The following is a description of a gene set: studied in species Homo sapiens from publication Indraccolo S, Pfeffer U, Minuzzo S, Esposito G, Roni V, Mandruzzato S, Ferrari N, Anfosso L, Dell'Eva R, Noonan DM, Chieco-Bianchi L, Albini A, Amadori A (PMID 17202376) IFNs are highly pleiotropic cytokines also endowed with marked anti-angiogenic activity. In this study, the mRNA expression profiles of endothelial cells (EC) exposed in vitro to IFN-alpha, IFN-beta, or IFN-gamma were determined. We found that in HUVEC as well as in other EC types genes were upregulated (>2-fold increase) by IFNs, including genes involved in the host response to RNA viruses, inflammation, and apoptosis. Interestingly, genes showed a >5-fold higher induction by IFN-alpha in EC compared to human fibroblasts; among them, the gene encoding the angiostatic chemokine CXCL11 was selectively induced by IFN-alpha in EC along with other genes associated with angiogenesis regulation, including CXCL10, TRAIL, and guanylate binding protein 1 (GBP-1). These transcriptional changes were confirmed and extended by quantitative PCR analysis and ELISA; whereas IFN-alpha and IFN-beta exerted virtually identical effects on transcriptome modulation, a differential gene regulation by type I and type II IFN emerged, especially as far as quantitative aspects were concerned. In vivo, IFN-alpha-producing tumors over-expressed murine CXCL10-11, GBP-1 and TRAIL, with evidence of CXCL11 production by tumor-associated EC. Overall, these findings improve our understanding of the anti-angiogenic effects of IFNs by showing that these cytokines trigger an anti-angiogenic transcriptional program in EC. Moreover, we suggest that quantitative differences in the magnitude of the transcriptional activation of IFNresponsive genes could form the basis for cell-specific transcriptional signatures. Human Gene Set: GSE3920_IFNA_VS_IFNG_TREATED_FIBROBLAST_DN Genes down-regulated in fibroblasts: interferon alpha versus IFNG., and this is the list of marker genes: RBM10, GPR146, BMAL1, HPGDS, TDRKH, LRRC49, PUS1, ARMCX2, GCNT2, TCF7, TMEM50B, PBK, ST8SIA1, INHA, ATP5F1A, GGT5, TUSC1, GTF2IRD1, TIMELESS, SNAI3, CYP2S1, MSTO1, IPO4, ELOVL6, PAQR8, MEX3B, FASN, TCOF1 (NCBI Gene Id 6949), TRPM6, PRKCB, AQP3, RAB3IP, DLG4, CATSPERD, LRRC75A, MAPK11, RRP12, METTL8, RORA, TGFBR3 (transforming growth factor beta receptor 3), NEURL1B, LARGE1, ID3, BIK, CLEC12A, F2RL1, MFHAS1, PLIN3, JAKMIP1, BACH2, IGFBP4, EMB, NSG2, PRSS12, MGST2, RFLNB, SYNPO, TREML2, PDLIM1, IDH2, LHX2, SIAH3, GUCY1B1, EEFSEC, TRMT1, IL6R, KCNIP2, TMEM176B, NT5E, CERK, UTP25, CD72, MYBBP1A, TRIB2 (tribbles pseudokinase 2), ZNRF1, SLC41A2, DPY19L3 (dpy-19 like C-mannosyltransferase 3), PPDPF, ODAD1, SESTD1, NAPEPLD, MYO10, LIPT2, ZNF519, MPP2, RAMP3, GPHN, FCRL1, MGLL, FOXRED2, ESPN, HIPK2, PES1, LIG1, APPL2, REXO2 (RNA exonuclease 2), ACSBG1, DDR1, NOL12, PCBP3 (NCBI Gene Id 54039), PKP4, CD93, FBXO17, ACTN1, DAPK1, NPAS2, ZFP1, PKIB, LRRC8D, TMEM176A, SMAD7, COX10, ALDH3B1, RORC, TBL3, NDRG1, ZC3H12B, MCM2, ZDHHC8, FANCG, LHPP, ECM1, ADAMTSL4, SH3BP5 (SH3 domain binding protein 5), RAPGEF4, RAMP1, SIPA1L2, NME1, VAX2, MGRN1, MRPS2, BCL2L12, CCR4, ADGRG5, IFNGR2, RIPK3, ARRB1, CCR7, MCM7, TMOD2, CARD9, IGF1R, TNFRSF25, NSMCE1, IL17RE, PIK3IP1, ARHGAP31, ALKBH2, SEMA4B, ADH1A, FAM124B, TPD52, NT5DC3, AP1M2, NOP56, CRY1, UBAP2, RGS10, CYSLTR1, SERP2, ITGA7 (NCBI Gene Id 81988), QTRT2, NLE1, SLC25A23, CTNNBL1, CRMP1, STAMBPL1, DEPDC1B, ETV3, STT3B (NCBI Gene Id 201595), STARD8, GCAT, SLC7A8, ITGA3, PHLDB1, TXK, LTB4R, POLR2L, SATB1, WDR77, FADS1, IFT80, MAML3, TANC1, NLK, PPP1R8, GPR183, ACP3